The following is a description of a gene set: The directed movement of organic anions into, out of or within a cell, or between cells, by means of some agent such as a transporter or pore. Organic anions are atoms or small molecules with a negative charge which contain carbon in covalent linkage. Mouse Gene Set: GOBP_ORGANIC_ANION_TRANSPORT species: Mus musculus, and this is the list of marker genes: Vps54, Slc22a20, Trh, Slco4c1, Cpt1b, Slc16a3, Snca (synuclein, alpha), Lyn, Tmem135, Nr0b2, Prkg1, Abcc5, Fabp3, Slc25a44, Il1b, Slc17a4, Slc25a38 (NCBI Gene Id 208638), Acsl3, Slc6a1, Edn1, Pianp, Slc17a5, Slc47a1, Fabp2, Spx, Ces1a, Stard10, Slc7a3 (solute carrier family 7 (cationic amino acid transporter, y+ system), member 3), Slc5a12, Sstr4, Slc36a1, Slc22a7, Nmur2, Slc6a14 (NCBI Gene Id 80646), Psen1, Slc16a1, Slc66a1, Slc38a3, Slc10a2, Panx1, Acsl5, Slc22a14, Slc1a6, Slc22a22, Kcnk2, Cptp, Trpc4 (NCBI Gene Id 53329), Slc22a18, Rgs4, Best1, Atp5pf, Irs2, Slco1a6, Gja1, Llgl2, Rgs2, Drd3, Mapk9, Umod, Slc2a10, Itgb1, Lhcgr, Slc16a6, Ces1f, Htr1a, Slc26a5, Slc25a29, Fabp5, Nf1, Ces1g, Oc90, Cd47 (NCBI Gene Id 78539), Pla2g12b, Slc27a2, Slc10a5, Slc51a, Pla2g3, Slc7a14, Slc1a5, Slc38a7, Mip, Slc10a4, Car4, Mfsd12, Slc16a4, Slco1a1, Slc38a9, Slc43a2, Slc1a1, Stxbp1, Slc36a4, Adora2a, Hnf1a, Slc6a11, Kcnj8, Calhm4, Sfxn3, Calhm1, Drd4, Abcc2, Slc6a8, Slc36a3, Cyp4a31, Slc3a2, Lrrc8e, Slc13a2, Cftr, Fabp6, Slc22a3 (NCBI Gene Id 20519), Casr, Slc35a2 (solute carrier family 35 (UDP-galactose transporter), member A2), Slc1a7, Pak1, Grin2b, Slco1a8, Slc1a4, Slc16a11, Selenon, Aqp9 (aquaporin 9), Slc25a4, Slc6a20a, Slc6a6, Slc25a42, Lep, Slc2a9, Slc27a1, Ces1d, Abcb1a, Agtr2, Kiss1r, Arg1, Slc22a1, Calhm2, Dtnbp1, Slc10a1, Sfxn1, Aqp8, Slc35a3, Acsl4, P2rx7, Abcg3, Map2k6, Slco1a5, Slc25a16, Slc25a11, Slc12a2, Syt4, Crabp2, Slc25a39, Rab3gap1, Slc38a4, Ces1e, Slco1a7, Abat, Slc25a31, Slc4a9, Slco6d1, Slc35d1, Slc6a20b, Dpysl2, Arhgef11 (NCBI Gene Id 236514), Slc25a19, Il1rn, Slco1c1 (solute carrier organic anion transporter family, member 1c1), Slc5a8, Slc35b2, Slc4a4, Sfxn5, Lrrc8a, Ptger3, Nfe2l1, Drd2, Mpc2, Slc46a2, Eprs1, Slc51b (NCBI Gene Id 330962), Slc2a5, Slc6a7, Pla2g10, Slc6a17 (solute carrier family 6 (neurotransmitter transporter), member 17), Slc23a1, Slc2a1, Plin2, Slc2a3, Slc17a8, Slc22a2, Slc4a10, Slc26a8, Agxt, Slc25a32, Slc52a2, Syk, Ttyh3, Ceacam2, Slc17a7, Crabp1, Hrh3, Fabp12, Slc4a3, Folr2, Ptgs2, Nr3c1, Arg2, Ptges, Cpt2, Ces1c, G6pc1, Slc16a14, Shoc2, Slc25a18 (solute carrier family 25 (mitochondrial carrier), member 18), Slc26a7, Slc25a23, Slc16a10, Adcy10, Fgf15, Folr1, Slc22a29, Slc22a27, Slc39a14, Fis1, Gnat2, Gipc1, Kmo, Cyp4a32 (NCBI Gene Id 674313), Slc7a2, Fabp9, Slc43a1, Slc17a3 (solute carrier family 17 (sodium phosphate), member 3), Slc23a2, Slc25a24, Emb, Slc35d2, Septin2, Tnf, Slco2b1, Slc25a40, Pla2r1, Mgst1, Slco1a4, Slc46a1, Slc5a6, Gabbr1, Repin1, Acsl6, Tmem241, Slc10a4-ps (solute carrier family 10 (sodium/bile acid cotransporter family), pseudogene), Slco2a1, Slc43a3, Pla2g2d, Ace (NCBI Gene Id 11421), Slco6c1, Slc22a6, Pla2g2a, Psap, Slc25a12, Arl6ip1, Pla2g2c, Fabp7, Cldn2, Rps6kb1, Pparg, Slc4a2, Slc7a13, Ntrk2, Slc35d3, Abcc10, Adora1, Slc25a54, Nmb, Pnpla8, Ucp2, Slc17a6, Acacb, Htr2c (NCBI Gene Id 15560), Trpv1, Slc44a4, Grm1, Abcc6, Slc10a7, Cyp7a1 (NCBI Gene Id 13122), Slc25a5, Slc35b3, Atp1a3, Lypla1, Got2, Tnfrsf11a, Mfsd2a, Best2, Cck, Abcg2, Slco6b1, Ace2, Lrrc8b, Slc22a19, Abcc8, Pla2g4a, Abcb1b, Ces1h, Slc7a5, Slc37a1, Avp, Agt, Slc27a5, Rbp7, Slc4a11, Slc35c2, Atp8b1, Myo6, Calhm6, Slc4a1, Grm2, Slc33a1, Slc26a1, Hrh2, Slc52a3, Proca1, Slc26a6, Slc37a4, Nos2, Slc6a13, Ntsr1, Slc2a4, Slc35a1, Ttyh1, Nfkbie, Rbp1, Slc10a6 (solute carrier family 10 (sodium/bile acid cotransporter family), member 6), Slc6a9, Slc25a10, Slco5a1, Mif, Nherf1, Slc25a25, Lrrc8c, Slc6a12, Slc19a1, Slc35b4, Slc7a10, Nr1h4, Slc17a9, Pla2g5, Asic3, Prkcd, Slc25a13, Slc25a15, Slc19a3, Bdkrb2, Slc2a7, Slc38a1, Slc7a4, Ttyh2, Tspo2, Cacnb4, Il1a, Lrrc8d, Kcnj10, Slc39a8, Ceacam1, Mpc1 (NCBI Gene Id 70697), Slc25a41, Slc13a3, Acsl1, Thbs1, Anxa1, Slc15a4, Pmp2, Npy5r, Cln8, Slc22a26 (solute carrier family 22 (organic cation transporter), member 26), Slc10a3, Mttp, Slc35b1, Slco4a1, Slc1a2, Ank, Abcd2 (NCBI Gene Id 26874), Slc2a8, Oxt, Ctns, Slc4a7, Slc7a11, Abcb4, Slc16a8, Ces1b, Slc7a6, Slc25a47, Slc7a8, Arl6ip5, Avpr1a, Slc3a1, Tnfsf11, Htr6, Mfsd10, Epm2a, Kcnk1 (potassium channel, subfamily K, member 1), Pla2g1b, Pla2g2f, Cd36, Slc22a13, Myc, Slc11a1, Slc6a15, Pla2g2e, Slc32a1, Slc25a17 (NCBI Gene Id 58177), Slc22a30, Slc37a2 (NCBI Gene Id 56857), Bdnf, Gfap, Nat3, Crot, Slc25a26, Slc27a6, Grm7, Apoe, Fabp4, Ppard, Slc1a3, Abcc4, Calhm3, Slc17a2, Slc38a5, Slc25a22, Slc25a21, Cltrn, Pdpn (podoplanin), Slc4a5, Slc25a20, Pla2g12a, Cln3, Slc22a12, Slc6a5, Pla2g4f, Slc17a1, Erfe, Rbp2, Apba1, Akt2, Slc7a1, Slco1b2, Slc16a9, Slc26a9, Slco3a1, Lrp2, Slc7a7, Slc7a9, Per2, Slc16a7, Cacna1a, Slc38a6, Sfxn2, Calhm5, Slc22a8, Slc22a28, Sv2a, Abcb11, Slc13a5, Abcd3, Slc36a2, Slc16a12, Abcc1, Slc26a3, Slc25a2, Akt1, Fabp1, Abcd1, Slc27a3, Slc25a1, Grik1, P2ry2, Slc27a4, Htr1b, Slc4a8, Avpr1b, Slc2a2, Abcd4 (ATP-binding cassette, sub-family D member 4), Pla2g6, Slc26a11 (NCBI Gene Id 268512), G6pc3, Abcc3, Slc38a2, Cyp4a10